Given this list of marker genes MT-CO1, HBA1, XDH, MB, AOX1, NOS2, NOS1, NOS3, here is a description of the gene set: Human Gene Set: WP_EFFECTS_OF_NITRIC_OXIDE Effects of nitric oxide studied in species Homo sapiens